Given this list of marker genes ATP6V0B, BEST3, NUP98, ORAI2, PANX3 (NCBI Gene Id 116337), DNAH11 (dynein axonemal heavy chain 11), PPARGC1A, USP31, DPYSL5, ZNF704, CHODL, KSR2, PRCD, IL18BP, SOBP, PIK3C2A, ANXA11, SRSF1, L2HGDH, VPS26B, BAGE2, RFX3, ADRA2B, C2CD5, PROX1, G3BP2, NR4A3, TMEM273, AVPR1A, MARK2, ZNF396, FLT3LG, FNBP1, AURKA, SERINC1 (serine incorporator 1), CAMLG, SYN3, ADAM10, SRSF3, TSPAN18, GPR85, CSTF2T, REXO2, CDH8, ATP1B1 (NCBI Gene Id 481), FRMPD4, MMRN2, CLDN1, SCPEP1, SCN2A, SLC52A3, LCP1, TPD52L1 (NCBI Gene Id 7164), NANOS1, DSC3, SNPH, here is a description of the gene set: from publication Chen Y, Wang X (PMID 31504780) Genes predicted to be targets of miRBase v22 microRNA hsa-miR-6836-3p in miRDB v6.0 with MirTarget v4 prediction scores > 80 (high confidence targets). Human Gene Set: MIR6836_3P species: Homo sapiens